The following is a description of a gene set: studied in species Mus musculus Mouse Gene Set: TABULA_MURIS_SENIS_LARGE_INTESTINE_ENTEROCYTE_OF_EPITHELIUM_OF_LARGE_INTESTINE_AGEING from publication Tabula Muris Consortium (PMID 32669714), and this is the list of marker genes: Cox5a, Rpl15, Mrps18c, Arg2, Zfp706, Znhit1, Med28, Ostf1, Hsp90ab1, Pam16, Ndufa10, Eif4a1, Plpp2, Tmed4 (NCBI Gene Id 67820), Yipf1, Krtcap2, Shisa5, Socs2, Vps28, S100a11, Arl2, Canx, Gnb2, Babam1, Rab24, Atp5mc3, Gstp2, Rps26, Pigr, Prdx3, Emc7, Emc10, Eef1g, Idh3b, Ywhah, Ciao2a, Txnl4a, Ube2n, Cct5 (chaperonin containing TCP1 subunit 5), Hnrnpa3, Tomm5, Chmp2a, Psmb10, Cdx2, Tex261, Rpl31, Rnaset2b, Dnajc15, Eif3m, Psenen, Chchd10, Psmb4, Mpdu1, Acads, Srsf11, Gadd45b (growth arrest and DNA-damage-inducible 45 beta), Chchd2, Ndufb7, Rpl41, Glrx5, Cycs, Ptp4a2, Unc50, Tmem238, Snrpa, Eif5, H1f0, Naca, Psme1, Anapc13, Zfas1, Bax, Pycr3, Rps27, Gale, Casp1, Rpl9, Plgrkt, S100a1, Twf1, Cmc1, Mtarc2 (mitochondrial amidoxime reducing component 2), Slc22a18, Trpv6, Clpp, Nedd8, Rpl11, Mrpl41, Mrps34, Ddrgk1, Cntfr, Ssna1, Ndufb2, Agpat5, Dctpp1, Ccs, H2az2, Mmp3, Adh1, Mrpl43, Hdac1, Etfb, Psmd4, Sri, Qng1, Dbndd2, Rpl7, Mrpl2, Sat1, Rpl29, Timm13, Ndufa5, Cldn3, Gadd45gip1, Pfdn2, Cyb5r3, Fkbp8, Polr2i (NCBI Gene Id 69920), Mrpl4, Uqcr10, Bloc1s1, Atp5pb, Fbp2, Mrpl55, Cgref1, Serbp1, 2510002D24Rik, Slc25a3 (solute carrier family 25 (mitochondrial carrier, phosphate carrier), member 3), Thap4, Nt5c, Ufc1, Rhoc, Psma1, Tmsb4x, Ndufc1, Pigp, Rnf225, Bri3, Tstd1, Rp9, Pgd, Pglyrp1, 2310011J03Rik, Snrpc, Sra1, Malsu1, Snx3, Polr2f, Rpl32, Prr13, Cox6b1, Ramac, Hmg20b, Gsdmc2, Rnf5 (ring finger protein 5), Ndufc2, Mtln, Ctsz, Rpl31-ps12, Sod2, Sqor, Dapk3, Fdx1, Espn, BC031181, Erp29, Rnf186, Chchd1, Pin1, Atp5f1e, Idnk, Eif3g, Aup1, Crb3, Atp6v1g1, Hsbp1, Cmbl, Psmc2, Mrpl28, Tmem219, Rrp1, Tex264, Sptssb, Phb1, Tpi1, Tsc22d1, Ccdc124, Sec61b, Pibf1, Pdcl3, Spr, Ndufa13, Tmem147, Mettl26 (methyltransferase like 26), Akr1c13, Rpl37a, Rnf7, Ube2m, Rpl22, Ech1, Ndufa9, Rack1, Krt19, Dynll2, Smim22, Rpl8, AA467197, Serpinb1a, Edf1, Rab4b, Ifi27, Snrnp70, Snrpd2, H2-D1, Ifi27l2b, Pllp, Kdelr2, Tmem45b, Eny2, Mdh2, Psma5, Mydgf, Prelid1, Selenos, Rps15a-ps4, Swi5, Cox6a1, Vti1b, Taldo1, Pttg1, Slirp, Myl12b, Mrpl53, Cdc123, Cldn7 (NCBI Gene Id 53624), Gpt, Lypla2, Agr2 (anterior gradient 2), Cox4i1, Eif5a, Atp5f1b, Cops6, Tmed10, Commd3, Cbr1 (NCBI Gene Id 224441), Osr2, Thoc7, Mrpl36, Phb2, Acot13, Tmem223, Nudt22, Nme2, Hsd17b8, Pgp, Nop53, Ndufb6, Trappc2l, Hspd1, Kxd1, Rpl6, Wdr89, Dnaja1, Prdx1, Vsig2, Aldh1b1, Map1lc3b, Htatip2, Creb3, Rtn4, Slc25a39, Sod1, Rpl28, Ndufaf3, Hras, Cideb, Gipc2, Rpl35, Acaa2, Klf13, Spcs1, Use1, Bdh1, Capg, Pold4, Tuba4a, Mrpl20, Gapdh, Rer1, Tmem126a, Hagh, Npc2 (NPC intracellular cholesterol transporter 2), Pa2g4, Hsd17b13, Gas5, Atp5mf, Ndufs3 (NADH:ubiquinone oxidoreductase core subunit S3), Rpl23, Clybl, Zmat5, Supt4a, Arpc5l, Rplp1, Ap1s1, Akr1c19, Fahd1, Rchy1, Stard3nl (NCBI Gene Id 76205), Csk, Yipf3, Sumo3, Ucp2, Nme3, Tmem11, Ptma, Atox1, Ube2l3, Krtcap3, Rps18, Eloc, Jpt1, Ndufb8, Psmb7 (proteasome (prosome, macropain) subunit, beta type 7), Szrd1, Hdgf, Fuom, Arpc4, Srsf7, Psmb6, Coq9, Copz1, Plekhj1, Suclg1, Fh1 (fumarate hydratase 1), Lamtor1, Nfkbib, Rpl36a, Aamdc, Rpl27a, Psmb5, Mrpl54, Ece1, Tmem59, Rps15a, Ubxn1, Vcf1, S100a16, Anp32a, Mrps21, Etfa, Syf2, Elof1, Raly, Ces1d, Ubl4a, Cela1, Mdp1, Echs1, Micos13, Atp5mc2, Rpl36al, Dcxr, Rps25, Ndufv2, Trir, Rpl22l1, Rfc2, Lsm4, Sft2d1, Parl, Gfus, Eif3h, Aprt, Nudt14, Hprt1, Dpcd, Ndufa12, Dnajc4 (DnaJ heat shock protein family (Hsp40) member C4), Mcu, Dad1, Mrps23, Galk1, Bsg, Pfdn6, Rpl27, Naxe, Ptpmt1, Rps6, Sdf2l1, Pdap1, Higd1a, Rps12, Prelid2, Cnpy2, Stard5, Ube2s, 1110065P20Rik, Pfdn5, Nudc, Psma3, Jund, Abhd6, Nsa2, Hmgb1 (high mobility group box 1), Smim20, Cks2, Tbca, 0610005C13Rik, Mrps25, Comt, Fam162a, Lamtor2, Car1, Ndufs7, Mrpl18, Sult1b1, Guca2b, Mrps33, Ndufab1, Rpl19, Lmo4, Sfn, Rabac1, Prxl2b, Psmd13, Uqcc3, Naxd, Cltb, Ndufb3, Mrpl51, Fam32a, Calm3, Plac8, Zfp781b, Hnrnpa0, Rps15a-ps6, Ndufs4 (NCBI Gene Id 77728), Uqcrc2, Defb37, Rpl4, Spag7, Trappc6a, Drap1, Rplp0, Sycn, Uqcrfs1, Alg5, Ndufa8 (NADH:ubiquinone oxidoreductase subunit A8), Srp9, Mrpl12, Dpy30, Glrx2, Dpm1, Rps5, Hmgn5, Taf9, Cct7, Rpl17, Nubp1, Bad, Ppia, Cda, Hint1, Il18, Srsf3, Sumo1, Fcgrt, Ndufa7, Krt18, Rps16 (NCBI Gene Id 30901), Gabarap, Dnlz, Calml4, Aldob, Ift20, Mtch2 (NCBI Gene Id 80443), Nipsnap3b, Rps11, Ndufa4, Fam3d, Ddost, Cisd3, Ppp4c, Paip2, Sdcbp2, Ube2a, Ppa2 (pyrophosphatase (inorganic) 2), Syngr2, Mcee, Cdc42, Eif5b, 2410006H16Rik, BC004004, Fam98c, Ccdc12, Rbm25, Eif1ax, Slc39a5, Tmbim4, Ifi30, Eef1a1, Uqcrh, Creg1, Fgfbp1 (NCBI Gene Id 14181), Tmed9, Mrpl40, Iscu, C1d, Cd9 (CD9 antigen), Ndufaf2, Tmem33, Ap2s1, Mix23, Ncl, Cebpzos, Ywhaq, Uqcc2, Pfn1, Rps27a, Cdk2ap2, Mrpl24, Sf3b5, Zmat2, 2610528J11Rik, Rps19bp1, Sec62, Psma2, Ccdc85b, Zcrb1, Gstk1, Tmem258, Smim14 (small integral membrane protein 14), Akt1s1, Atp5f1c, Dgcr6, Cryl1, Acot8, Mt1, Rpl18a, Ndufa11, Sdc4, Mvb12a, Stx8, Rpl5, Tomm20 (NCBI Gene Id 67952), Mrpl42 (NCBI Gene Id 72550), Ndufa2, Tpd52l2, Nipsnap2, Rpl24, Rps3a1, Myl6, Acaa1a, Rpl3, Gstt1, Rnf181, Mrpl57, Clta, Macroh2a1, Commd1, Tspo, Psmc5, Gclm, Llph, Napa, Tomm6, Trappc4, Sult1a1 (sulfotransferase family 1A, phenol-preferring, member 1), Adh5, Rps20, Reep5, Jtb, Sarnp, Atraid, Msra, Ap1m2 (NCBI Gene Id 52148), Rab11a, H13, Eif6, Mrps14, Cfl1, Gna11, H2aj, Aimp1 (NCBI Gene Id 320948), Gsta1, Car2, Uqcr11, Ubxn4, Sar1b, Hypk, Vdac2, Csnk2b, Hadh, Tomm22, Guk1, Lman2, Psap, Map1lc3a, Nagk, Stmp1, Slc51a, Cyb5b, Snu13, Pgk1, Rps4x, Tmed3, Mpc1, Ywhae, Srsf5, Ier3ip1, Polr2j, Rwdd1, Ssu72, Coa3, Pycard, Mrps26, Mrpl27, Tma7, Tufm, Park7, Carhsp1 (NCBI Gene Id 66879), Aldoa (aldolase A, fructose-bisphosphate), Psma6, Ssr4 (signal sequence receptor, delta), Rps8, Adtrp, 2310039H08Rik, Gtf3c6, Mrpl58, Gabarapl2, Iah1, Surf1, Tbrg1, Ang, Trappc3, Spcs2, Cox7a2, Hmgcs2, Tomm40, Ftl1, Atg101, Rab5if, Emg1, Nop10, Tle5, Naa38, Cirbp, Fkbp2, Rplp2, Tmt1a, Tspan1, Mrps16, Emc4, Timm23, Cox16, Mpv17l2, Ppa1, Mrpl21, Capzb, Tmsb10, Slc51b, Polr2c, Fa2h, Hcfc1r1, Atp6v1f, Tbcb (tubulin folding cofactor B), Glod5 (glyoxalase domain containing 5), Dbi (diazepam binding inhibitor), Dynlrb1 (NCBI Gene Id 99273), Grcc10, Rpl18, Tmem98, Rpl35a, Ccdc107, Mt2, Ociad1 (OCIA domain containing 1), Cnbp, Golt1a, Cstb (cystatin B), Uqcrc1, Nol7, Gabrr2, Ndufs2, Wdr83os, Serhl (NCBI Gene Id 93962), Pals2, Rbis, Cth (NCBI Gene Id 99582), D8Ertd738e, Clic1, Smagp, Vamp8, Gpd1, Psmc3 (proteasome (prosome, macropain) 26S subunit, ATPase 3, NCBI Gene Id 19182), Gsto1, Gpx4, Rnh1, Oaz1, Stub1, Pnp2, Ociad2, Cox7a2l, Hao2, Atp5f1d, Atp5po, Cisd1, Mpnd, Ssr2, Tm4sf20, Aqp11, Polr1c, Churc1, Nqo1, Sdhd, Tmem171, Car9, Tmem205, Gnpnat1, Ndufs8, Ncbp2as2, Hmgcl, Tecr, Sdf4, Ppcs, Hint2, Rpl13a, Wbp1, Mea1, Pcbp2, Rpl10a, Pts, Bbln, Tmco1, 0610010K14Rik, Nudt19, Pdcd6, Slc25a11, Pcbd2, Bud31, Gcg, Rab8a, Mcrip2, Cdc37, Tst, Arpc1b, Slc25a5, Mocs2, Sugt1, Ndufs6, Fibp, Nans, U2af1, Dpm3 (NCBI Gene Id 99854), Hsd17b10, Prnp, Sin3b, Anapc11, Dap3, Mrpl34, Tnfrsf9, Tuba1b, Decr1, Pmvk, Cplx1, Mif4gd, Rps17, Atp5if1, Eif3f, Tpgs1, Qdpr, Cox14, Eef1b2, Gstt3, Nenf, Idh3g, Rala, H3f3b, Manf, Mien1, Uba52, Spink4, Psmd7, Rac1, Ebp, Prrg2, Dnajc8 (DnaJ heat shock protein family (Hsp40) member C8), Cops9, Romo1, Ormdl2, Ctsb, Mrps36, Tmem234, Polr1d, Rab4a, Ndufb10, Nabp2, Ptms, Ubb, Anapc16, 2210016L21Rik, Reg4, Gss, Mrps12, Gstt2, Trappc2b, Hmgb2, Klk1, Lamtor4, Cbr3, Cyba, Arpp19, Atp5pd, Rbm3, Krt7, Prdx2, Gemin7, Erh, Pex16 (NCBI Gene Id 228367), Pla2g10, Vps29, Eif3k, Rpl23a, Cox6c, Eif4e2, Bola2, Sub1, Ms4a8a, H3f3a, Psme2, Mrpl30, Gnb1, Scp2, Bola3, Triap1, Cyb5a, Tmem256, Adrm1, Snapc5, Lgr4, Commd6, Rps13, Psma4, Hsd17b2, Bag1, Gtf2h5, Arhgdia, Arf5, Zfand2b, Vps25, Mlf2, Rbx1, Lgals4, Tmem208, Ddx39b, Ndufb5, Saysd1, Hnrnpab, Mrps15, Phf5a, Gm3336, Rbm42, Srp14, Rpl14, Sdhb, Alad, Pfdn1, Gpx1, Laptm4a, Rps24 (NCBI Gene Id 20088), B2m, Ndufaf8 (NADH:ubiquinone oxidoreductase complex assembly factor 8), Mdh1, Tpt1, Fabp2, Cst3, Sdhc, Mif, Dnajc19, Gfer, Fkbp4, Commd4, Tmem242, Fkbp1a, Eci2, Atp5f1a, Uqcrq, Ctdnep1, Sys1, Cox8a, Ak2, 1810009A15Rik, Gm15401, Sec61g (SEC61 translocon subunit gamma), Ptges3, Sem1, Immp1l, Abhd14b, Snrpd3, Gatad1, Vasp, Cox20, Cd63, Macrod1, Ssr1, Mrpl23, Alkbh7, Myl12a, Cfdp1, Snrpe, Ppdpf, Ifi35, Selenow, Dhrs7b, Rpl21, Atp5mg, Wbp2, Gstm1, Otub1, Nfkbia, Dctn3, Eif3i, Prelid3b, Ccdc141, Tmem134, Pebp1, Glrx3, Vdac3, Sh3bgrl3, Mri1, Ndufb4, Pkig, Mlec, Fdps, Lgals9, Tspan8, Arl4a, Lsm6 (LSM6 homolog, U6 small nuclear RNA and mRNA degradation associated), Pgam1, Ndufv1, Acp5, Ppp1ca, Set, Ddt, Atp6v0e, Npm1, Snrpf, Ubb-ps, Rps19, Fmc1, Tmem259, Sec11a, Mrpl17, Fuca1, Dhrs4, Polr2l, Rheb, Mgst3, Rnase4, Ndufb9, Rpl36, Hnrnpa2b1, Pex11g, Higd2a, Grpel1, 1810065E05Rik, Gstp1, Pdcd5, Psmb3, Ypel3, Micos10, Mpc2, Ethe1, Timm17b, Ube2v1, Esd, Noxo1, Gipc1, Rps14, Dph3, Ost4 (NCBI Gene Id 67695), Calm2, Psma7, Elp5, Scand1, Abhd17a, Asl, Slx1b, Pnp, Abhd11, Cdc26, Rps7, Nat9, Ppfia3, Psmc4, Antkmt, Acp1, Cib1, Chmp6, Mrpl14, Tradd, Tm2d2, Tmem160, Ybx1, Sec11c, Tax1bp3, Emc6, Cystm1, Mrpl52, Trappc1, Sec13, Cd81, Rab25, Spint2, Mrpl15, Eef1d, Sptssa, Mrpl33, Ppp1r11, Smdt1, Trappc5, Srek1ip1, Selenok, Rpl12, Cuta, Gtf2a2, Rpl13, Smim7, Pafah1b3, Samm50, Sumo2, Igbp1, Svbp, Hnrnpc, Khk, Tmt1b, Akr1a1, Ap2a2, Timm17a, Gpr15lg, Acot7, Psmb1, Smim24, Tmem252, Rpl10 (NCBI Gene Id 28147), Degs2, Rps9, H2az1, Kdelr1, Tm2d1 (NCBI Gene Id 94043), Gsdmc4, Rps15, Rnasek, Abracl, Akr1b8, Rnaseh2c, Tubb4b, Pgls (NCBI Gene Id 66171), Csrp2, Tusc2, Aamp, Aurkaip1, Akr1c12, Prap1, Rab5c, Polr2k, Hspe1, Timm44, Mrps24, Txn1, Adam28, Cyc1, Mpst, Idh1 (NCBI Gene Id 98427), Klf5, Arl6ip5, Dnpep, Akr7a5, Rpsa, Mrps18a, Ube2i, Stk16, F11r, Fis1, Hexa, Cyp2d26, Polr2e, Glo1, Akr1e1, Bcap31, Pnkd, Btf3, Rpp21, Mkrn2os (NCBI Gene Id 70291), R3hdm4, Mptx1, Elovl1, Gmds, Gstm5, Tubb5, Fermt1, Sf3b6, Snrpg, Yif1a, Rpl7a, Rps2, Fth1, Tmem50a, Map2k2, Eci1, Lurap1l, Tmem54, Anp32b, Ier2, Pomp (proteasome maturation protein), Ces1g, Ces1f, Psmb2, Txndc9, Tnni1, Atp5pf (ATP synthase peripheral stalk subunit F6), Cdc42ep5, Selenom, Mrps7, Rtraf, Banf1, Pigx, Ciao2b, Rex1bd, Cnnm4, Atp6v0b, Ostc, Sdhaf4, Arpc3, Rps3, Zfpl1, Hyi, Mrpl32, Lgals3, Eif3e, Pmm1, Rps23, Cope, Prdx5, Ergic3, Cdx1, Rbm8a, Hsp90aa1, Upk1a, Chchd7 (coiled-coil-helix-coiled-coil-helix domain containing 7), Dmbt1, Brk1, Cox19 (NCBI Gene Id 70066), Cenpx, Ndufb11, Ube2k, Cnih4, Ran, Gng12, Pigbos1, Psmd8, Stap2, Mgst2, Lamtor5, Calm1, Snrpb, Rps10, Tmem14c, Txndc17, Timm8b, Blvrb, Elob, Bola1, Rps27l, Mapk13, Txn2, Tcea3, Paqr5, Serf2, Erg28, Tagln2, Ppib, Ubl7 (NCBI Gene Id 69459), Atp5mc1